Given this list of marker genes Rps28, Mterf3 (NCBI Gene Id 66410), Mrps2, Nip7, Eif6, Nsun4 (NCBI Gene Id 72181), Rps25, Eif2a, Rps6-ps4, Ddx3x, Eif5b, Efl1, Abt1, Mrps7, Eif5, Mcat, mt-Rnr2, Rcc1l, Rpf2, D1Pas1, Rps27, mt-Rnr1, Rrs1, Rps5, Nop53, Bop1, Rps19, Mpv17l, Rpl38, Rpl24, Ddx28 (DEAD box helicase 28), Pwp2, Mettl17, Xrcc5, Fau, Ngrn, Rpl11, Eif1ax (eukaryotic translation initiation factor 1A, X-linked), Surf6, Mdn1, Rps6, Dhx30, Rps15, C1qbp, Eif1a, Rps14, Dhx37, Rpl5, Rrp7a, Brix1, Mrto4, Dhx29, Mterf4, Mrm2, Rps27l, Rpsa, Fastkd2, Rpl10l, Prkdc, Nop2, Noa1, Eral1, Mpv17l2, Sbds, here is a description of the gene set: Mouse Gene Set: GOBP_RIBOSOME_ASSEMBLY The aggregation, arrangement and bonding together of the mature ribosome and of its subunits. species: Mus musculus